The following is a description of a gene set: Human Gene Set: GSE32986_GMCSF_VS_GMCSF_AND_CURDLAN_HIGHDOSE_STIM_DC_UP species: Homo sapiens Genes up-regulated in bone marrow-derived dendritic cells CSF2 versus CSF2 and high dose of 1,3-beta-D-oligoglucan. A simultaneous engagement of different pathogen recognition receptors provides a tailor made adaptive immunity for an efficient defence against distinct pathogens. For example, cross talk of TLR and c-type lectin signalling effectively shapes distinct gene expression patterns by integrating the signals at the level of NF-κB. Here, we extend this principle to a strong synergism between the Dectin-1 agonist, curdlan, and an inflammatory growth factor, GM-CSF. Both together act in synergy in inducing a strong inflammatory signature which converts immature DCs to potent effector DCs. A variety of cytokines (IL-1β, IL-6, TNF-α, IL-2 and IL-12p70), costimulatory molecules (CD80, CD86, CD40 and CD70), chemokines (CxCl1, CxCl2, CxCl3, CCl12, CCl17) as well as receptors and molecules involved in fugal recognition and immunity such as Mincle, Dectin-1, Dectin-2 and Pentraxin 3 are strongly up-regulated in DC treated simultaneously with curdlan and GM-CSF. The synergistic effect of both stimuli resulted in strong IKBα phosphorylation, in its rapid degradation and in enhanced nuclear translocation of all NF-κB subunits. We further identified MAPK ERK, as one possible integration site of both signals, since its phosphorylation was clearly augmented when curdlan was co-applied with GM-CSF. Our data demonstrate that the immunomodulatory activity of curdlan requires an additional signal provided by GM-CSF to successfully initiate a robust β-glucan specific cytokine and chemokine response. The integration of both signals clearly prime and tailor a more effective innate and adaptive response against invading microbes and fungi. from publication Min L, Isa SA, Fam WN, Sze SK, Beretta O, Mortellaro A, Ruedl C (PMID 22250091), and this is the list of marker genes: RHOB, CERT1, CD200R1, WWC2, NSD3, SDC3, ZNF438, TRIM14, PTPN21, BBS5, RCOR3, MRTFB, CD300C, KRTAP13-2, RMND1, ZBTB16, SLC36A4, SLC26A11, RAP2A, POLR2G, RAB3IL1, DUBR, CTSK, ARRDC3, LONRF3, TSTD1, TMEM86A, RO60, ENC1, NATD1, CD48, AQP7, ARHGAP24, MTLN, HK2, TMEM50A, ADAM18, SNX24, RNF144B, GATM, SLC18B1, MAFB, ATP6V0D1 (ATPase H+ transporting V0 subunit d1), SLC40A1, LAMP1, GPR155, MTO1, RGS2, DDX27, AMACR, CD93, TMEM87B, IGF1, MXI1, PPP1R3B, TTC39A, CRYL1, MINDY2, PGRMC1, EHD4, CTSA, LTB4R2, GALNT4, GAK, VWF, FBXO32, MOCOS, HACD4, PREPL, RAB11FIP5, CPEB3, GAS6, RTL5, GPT2 (NCBI Gene Id 84706), MERTK, MFSD12, TP53INP1, HIPK2, REPS2, FGF3, RASA1, PSEN2, LPAR6, PHYH, ST6GAL1, PDXK, NPC2, SLC10A7, MXD4, CDS2, ABCC3, UBE2T, GMNN, SENP8, IL1RL2, MRM2, SPRY2, TBC1D24, TIMP2, ABHD12, GYG1, TMEM230, PDSS1, QDPR, APPL2, UGDH, SORD, PI4K2A, RRAGC, DBP, METTL21A, TPST1, CPT1A, TBC1D2, MYO1E, ARPC1B, ASB4, IL11RA, ZNF839, FAM110B, CLMP, ANGPTL4, TESK2, THBD, KIAA0513, FBXO8, APH1B, MBTPS2, HEBP1, OSBPL11, GLB1, TSC22D3, VPS41, TRIM44, TATDN3, TM6SF1, LRP4 (LDL receptor related protein 4), WDR7, PLA2G15, MFSD11, HMX1, KIAA0930, TEC, RCAN3, RRAGD, TMEM41B, DNA2, PPP1R12C, CDPF1, CTC1, CEBPA, ABCG1, MMAA, MEAK7, HEY1, PRRC1, YPEL2, C6orf62, COMT, SLC35F6, PRMT9, CNKSR3, NR1D2 (NCBI Gene Id 9975), FAM110C, MLKL, MDFIC, SOCS6, G3BP2, DENND2A, ATP6V1B2, S1PR1, GAS8, FGF13, FAM89B, C19orf38 (NCBI Gene Id 255809), LEPROTL1, CERK, GAB2, FAM219B, STXBP5, GADD45G, DPP7, CNRIP1, NQO2, ANXA3, SYNGR1, ARHGAP19, MAPK9, MYLIP, KIF3A, PDE7B, CAMLG, BLVRA, NRBF2, PGD, SLC3A2, TCEAL8, GUSB, SLC16A6, PTPN20